The following is a description of a gene set: Human Gene Set: GOCC_BOX_H_ACA_TELOMERASE_RNP_COMPLEX species: Homo sapiens A box H/ACA ribonucleoprotein complex that contains the RNA component of vertebrate telomerase, the enzyme essential for the replication of chromosome termini in most eukaryotes. This ribonucleoprotein complex is a structural box H/ACA RNP, which does not have the catalytic pseudouridylation function shared by the majority of H/ACA RNPs present in the cell., and this is the list of marker genes: DKC1, GAR1, NOP10, NHP2, TERC